The following is a description of a gene set: species: Mus musculus A process of secretion by a cell that results in the release of intracellular molecules (e.g. hormones, matrix proteins) contained within a membrane-bounded vesicle. Exocytosis can occur either by full fusion, when the vesicle collapses into the plasma membrane, or by a kiss-and-run mechanism that involves the formation of a transient contact, a pore, between a granule (for example of chromaffin cells) and the plasma membrane. The latter process most of the time leads to only partial secretion of the granule content. Exocytosis begins with steps that prepare vesicles for fusion with the membrane (tethering and docking) and ends when molecules are secreted from the cell. Mouse Gene Set: GOBP_EXOCYTOSIS, and this is the list of marker genes: Ppp3cb, Septin4, Slc18a2, Htr1b, Trarg1, Chmp2a, Lin7b, Erc1, Synj1, Bloc1s6, Il13, Ywhaz, Myo5a, Ighe, Pdpk1, Syk, Kcnh1, Vamp3, S100a10, Ppfia2, Ralb, Itgam, Nlgn1, Fes, Cacna1e, Dtnbp1, Chga, Syt5, Cacna1a, Lrrk2, Gnao1, Clasp1, Syt1, Git2, Itgb2l, Prkaca, Llgl2, Sptbn2, Dnm1l, Sdc4, Hyal3, Baiap3, Fcgr4, P2ry2 (NCBI Gene Id 18442), Kcnb1, Wnt7a, Lat2, Anxa2, Snap25, Rab8b, Gnai2, Ccr2, Rims3, Lyn, Adora3, Scamp5 (secretory carrier membrane protein 5), Rab11fip1, Scrib, Nppc (NCBI Gene Id 18159), Rab44, Lgals9, Mical1, Sacm1l, Milr1, Rph3a, Exoc3l, Sytl5, Cacna1d, Rab3c, Lamp1, Cops5, Snap23, Rab27b, Cd84, Syde1, Scn11a, Syt15, Prkcb, Anxa1, Hmox1, Sdc1, Rala, Stxbp5l, Prkca, Prrt2, Myh10, Pou5f1, Snx4, Adra2a, Stxbp2, Orai1, Ccl8, Rims4, Fga, Syt10, Tnfaip2, Pld2, Mrgprx2, Il1rapl1, Arl8b, Hgs, Syt8, Sytl2, Washc3, Grxcr1, Eqtn, Scrn1, Prss12, Ncs1, Adora2b, Ptgdr, Stx17, Syngr3, Fmr1, Lat, Stx19, Syt13, Rab11a, Rims2, Pik3c2a, Tsg101, Gpr15lg, Sv2c, Vamp9, Fgr, Syt4, Nsf, Pram1, Snapin, Pla2g3, Ccl3, Rab11b, P2ry4, Cbl, Kctd9, Exoc3, Htr1d, Unc13d, Exoc6, Cspg5, Rab40c, Mia3, Syp, Cplane2, Cacna1h, Rab21, Septin5, Kcnq3, Tac4, Cplx2, Gpr151, Vps4b, Il4, Pex5l, Snca, Rab11fip2, Exoc3l4, Vps4a, Rab3gap1, Cadps2, Tpcn2, Kit, Cacna1g, Syn2, Unc13b, Rab3d, Wdr41, Rab8a, Sytl3, Pla2g6, Rufy4, Rab12, Stx2, Rac2, Washc1, Cd160, Vamp2, Gab2, Cbarp, Pak1, Abca12, Snap47, Pip5k1c, Nlrp5, Cdk16 (NCBI Gene Id 18555), Gcgr (glucagon receptor), Cplx1 (NCBI Gene Id 12889), Epb41l1, Osbpl2, Cplx4, Exph5, Rab10 (RAB10, member RAS oncogene family), Lgi3, Syt7, Tmed10, Clnk, Tcp11, Prkn, Rest, Nkg7, Cd177, Stx1a (syntaxin 1A (brain)), Cd300a, Braf, Mical3, Exoc5, Exoc2, Pclo, Btk, Ceacam1, Coro1a, C9orf72, Clasp2, Ykt6, Sytl1, Rap1b, Smcr8, Arf1, Trim72, Prepl, Cadps, Tspan18, Rabgef1, Ptafr, Scamp1, Rap1a, Tph1, P2rx7, Sphk2, Ccl5, Cacna1i, Doc2a, Rab31, Cask, Vsnl1, Rab9, Slc4a8, D6Wsu163e, Rab25, F2rl1, Prkcg, Rims1, Cplx3, P2ry1, Exoc1, Cftr, Tprg1l, Sytl4 (synaptotagmin-like 4), Ccr1, Snap29, P2rx2, Cltrn, Notch1, Pi4k2a, Atp2a2, Mrgprb1, Fgg, Rab37, Plek, Crhbp, Arhgap17, Sv2a, P2rx1, Ptgds, Tmem63b, Sdf4, Gata1, Sv2b, Erc2, Steap3, Doc2g, Npy (NCBI Gene Id 68398), Syt17, Exoc8, Sycn, Septin1, Stx4a, Atp13a2, Pikfyve, Ppfia3, Syngr2, Ap1g1, Lin7a, Il4ra, Ms4a2, Cdk5r2, Rab3b, Stx3, Trim9, Exoc4, Nkd2, Syngr1, Rab3a, Vamp1, Washc5, Myh9, Dvl1, Llgl1 (NCBI Gene Id 16897), Rab2b, Vps18, Srcin1, Syt6, Grp, Exoc6b, Ctbp2, Kcnq2, Myo5b, Vps41, Napa, Steap2, Zp3, Rab33b, Rab11fip5, Itgb2, Grik5, Lin7c, Bcl2l1, Camk2a, Syn1, Syt9, Rimbp2, Lypd10, Tmem167b, Stxbp1, Itsn1, Cacnb4, Napb, Fcer1g, Rapgef4, Rasgrp1, Rab26, Arfgef2, Myo1g, Fbxo45, Rab13, Pfn2, Bcr, Rab27a, Rph3al, Cacna1b, Rab40b, Nckap1l, Snx19, Lypd11, Trappc11, Brsk2, Npy1r, Stxbp3, Stxbp5, Sdcbp, Fcer1a, Nppa, Nr4a3, Psen1, Smpd3, Il13ra2, Git1, Crhr1, Rab5a, Rab15, Myo1f, Txlna, Syt3, Atp9a, Cacna1c, Doc2b, Spi1, Unc13a, Syt11, Vamp8, Abr, Ccr1l1, Fgb, Fbxl20, Hck, Brsk1, Anxa3 (annexin A3), Vps11, Exoc7, Cdk5, Pdcd6ip, Stx11, Ncam1, Syt2, Efr3a, Syt12, Exoc3l2, Stx1b, Tmem79, Gata2, Unc13c, Tmem167, Otof, Rab7, Snf8, Stam, Hap1, Wipf3, Foxf1 (forkhead box F1)